The following is a description of a gene set: The process whose specific outcome is the progression of a cartilage element over time, from its formation to the mature structure. Cartilage elements are skeletal elements that consist of connective tissue dominated by extracellular matrix containing collagen type II and large amounts of proteoglycan, particularly chondroitin sulfate. species: Homo sapiens Human Gene Set: GOBP_CARTILAGE_DEVELOPMENT, and this is the list of marker genes: COL11A2, MEX3C, ECM1, BBS2 (NCBI Gene Id 583), SMAD1, ITGB8, CHADL, CD44, BMP8A, TIMP1 (NCBI Gene Id 7076), CER1, TRPS1, SOX5, SRF, CHSY1 (chondroitin sulfate synthase 1), TGFB1, RSPO2, CCN3, BMP5, AMELX, MKKS, RFLNA, CHRDL2, CYTL1, BBS1, CHST11, SLC26A2, EXT2, UNCX, RUNX3, WNT7A, HYAL2, STC1, SLC39A14, MATN3, NPPC, WNT9A (NCBI Gene Id 92832), GHRL, TRIP11, ZEB1, PRKG2, BMP1, TAPT1, SCX, FGF18, ZBTB16, GDF6, CTSK, ADAMTS12, BMP3, GLI3, NKX3-2 (NCBI Gene Id 579), NPR2, FRZB, MIR21, HOXA11, FGFR3, SMAD3, RARB, SNX19, MAPK3, COL1A1, HYAL3, SOX9, WNT10B, COL3A1, BMP4, HOXA3, FOSL2, FGF9, MUSTN1, EPYC, OSR1, GATA3, COL6A1, IFT80, OGN, PTH, SCIN, MAPK14, SERPINH1, PKDCC, WNT2B, EFEMP1, SMAD5, RUNX1, ACVRL1, SOX6, LUM, CTNNB1, COMP, OPTC, COL11A1, ARID5A, EDN1, DDRGK1, FGF4, CSGALNACT1, HES5, SNAI1, HAND1, IHH, SMAD7, DLX2, CCN2, CBS, BMP2, LEP, POC1A, EIF2AK3 (eukaryotic translation initiation factor 2 alpha kinase 3), WNT7B, MBOAT2, LTBP3, OTOR, LOXL2, PITX1, WNT11, BMP10, SULF2, EXT1, NFATC2, BMP8B, CHI3L1, GDF5, MYF5, POR, FGF6, GALNT3, BMPR1A, MEF2C, ENSG00000274276, SATB2, IL17F, MDK, MYCN, FGF2, ADGRG6 (NCBI Gene Id 57211), RARG, PTHLH, GREM1, TGFBI, SNAI2, BGN, BMP6, HMGA2, TGFB2, COL27A1, SIX2, NOG, BPNT2, HYAL1, TGFBR2, RARA, AXIN2, PTPN11, LNPK, HAND2, SNORC, WNT5B, MMP13, PBXIP1 (NCBI Gene Id 57326), HOXC4 (homeobox C4), NFIB, ATP7A, BMP7, MSX1, GLG1 (NCBI Gene Id 2734, golgi glycoprotein 1), SFRP2, TWSG1, MATN1, BMPR1B, MAF, GHR, NR5A2, CNMD, OSR2, HOXB3, CCN1, CCN4, WNT5A (Wnt family member 5A), KAT2A, HOXD3, MSX2, MGP, PAX7, COL2A1, NFIA, ADAMTS7, THRA, THBS3, SHOX2, PKD1, EVC (EvC ciliary complex subunit 1), HOXA5, SULF1, BARX2, CREB3L2, GDF2, TRPV4, RFLNB, ERRFI1, PRRX1, TGFBR1, PTH1R, FGFR1, GPLD1, RB1, RUNX2, ATF2, BMPR2, ZNF219, HIF1A, ZMPSTE24, SMPD3 (NCBI Gene Id 79756), TSKU